The following is a description of a gene set: studied in species Homo sapiens from publication Chen Y, Wang X (PMID 31504780) Genes predicted to be targets of miRBase v22 microRNA hsa-miR-7853-5p in miRDB v6.0 with MirTarget v4 prediction scores > 80 (high confidence targets). Human Gene Set: MIR7853_5P, and this is the list of marker genes: COPS8, AMOTL2, MECP2, WASHC4, USP15, ARHGEF7, WAC, HMMR, AGO1, RAMAC, PRDM1, USP37, TEX2, BMP2K, HIPK3, MSANTD4, CITED2, ARPP19, REST, STXBP5L, UGGT1, CCDC34, ATP8A1, AP1S3, DGKH, RCBTB1, ST13, GPCPD1, LMO7, RHOBTB1, TAF9B, CDK12, SMNDC1, FSD1L, ROR1, MSI2, SRGAP1, FNIP2, EPHA5, COQ9, PAN3, FIGN, ITGB6 (NCBI Gene Id 3694), L3MBTL3, F13A1, TM9SF2, BRWD3, BICRAL, DCUN1D4, UBE2K (NCBI Gene Id 84819), ZIC3, ZNHIT6, C18orf63, MIER3, STT3B, DNAJB14, RAPGEF2, SLC44A1, ATP2C1, TES, WWP1, SLITRK5 (SLIT and NTRK like family member 5), GJA1, PPFIA2, RNF38, TMEM265, SUZ12, FMO1, SSH2, GRAMD2B, GPR137C, KBTBD8, POU4F1, ELK4, KIF5B, ACADSB, FGFBP3, DENND6A, MAP3K8, ITGA6, SLC10A7, GPR12, PPP3R1, SLC4A1AP, CLDN10, CELF1, ZNF24, CD274, TMEM64, MRAP2, SLC12A2, SCAPER, KHDC4, TJP1, TFCP2, SPATA13, TAF2, SLC7A11, CREB5, LDLRAD3, LIMCH1 (LIM and calponin homology domains 1), INPP5F, PLCL1, ATAD2B, TMEM97, AFF2, ADAT2, LPIN1, PJA1, GOLT1B, MICOS10, FUT9, QDPR, MGAT4B, KIF1C, KIAA0408, BCL11B, CD40LG, RNF170, CDC14A, AMDHD1, PRPF40A, CALM1, CDH2, ODC1, SDCBP, CHRNA9, SSBP2, ITM2B, FAT1, CARMIL1, ZNF302 (NCBI Gene Id 82167), PTPN11, PRKAB2, RAB2A, ACSL3, CYP51A1, ZEB1, SCN7A, PARP14, NABP1, TRA2B, NUP50, PDE4D, KRT1, POMP, C2orf68, TM9SF3, CBL, CRAMP1, HNRNPK (NCBI Gene Id 3190), PHEX, KCNJ13 (potassium inwardly rectifying channel subfamily J member 13), DCX (NCBI Gene Id 1641), FLRT2, SELL, TRAM1, EPHA4, SEL1L, DUSP16, NKAIN2, C17orf58, MED14, SHISA9, PBX1, MAGI1, ABCA9, SLF2, CAB39, DMRTA1, MDM4, ASAP2, TBL1XR1, FASLG, ULK2, KRAS (KRAS proto-oncogene, GTPase), TULP4, API5, UBE2V1, CD24, UBE2D2, ABTB3, ZNF532, BMPR1A, SLC5A1, LEPR, CP, TEAD1, STARD13, NEK1, ST8SIA3, MLLT3, CRYL1, ACER3, TEKT3, NEDD4, SLC17A6, OSTM1, GNG12, SPATS2L, ZNF33B (zinc finger protein 33B), PTPN13, OGG1, RAP2C, TTC3, RBMS3, RPP14, DET1, ENDOU, MORF4L2, VCL, PPP1CB, CRYZL1, CDC5L, NRXN1 (NCBI Gene Id 9378), STXBP5, PCSK5, SPOCK1, GDNF, NSL1, YTHDF3, EIF4G2 (eukaryotic translation initiation factor 4 gamma 2)